Given this list of marker genes ALKBH1, FARS2, THG1L, RARS1, MRPS27, IARS2, NSUN3, EEFSEC, TRMT10B, ELP5, TRMT1L, RPL35A, TRNAU1AP, EARS2, EIF5B, NSUN2 (NOP2/Sun RNA methyltransferase 2), SLFN11, SSB, RPUSD4, TRMU, EIF1AX, KARS1, EIF2AK4, AARS1 (NCBI Gene Id 16), NAT10, PSTK, TERT, AIMP1, SARS2, FARSA, EIF2S3B, GTPBP1, EIF1AY, TRMT1, ALKBH8, DTD1, MTRFR, PUS1, CARS1, THUMPD3, HSD17B10, DTD2, TRMT10C, ELP3, XPO5, EIF2A, MARS1, IGHMBP2, METTL1, DARS2 (NCBI Gene Id 55157), DALRD3 (NCBI Gene Id 55152), SEPSECS, YRDC, XPOT, TYW5, IARS1, NEMF, CTU1, MTRES1, CTU2, SARS1, TARS1, DUS2, TRMT10A, YARS1, YARS2, ELP1, PTRH1, WDR6, QTRT2, EIF2S3, TRMT11, AARS2, IFIT5, GTSF1, SLFN13, TRMT9B, NSUN6, PTCD1, EEF1A1, TRNT1, here is a description of the gene set: studied in species Homo sapiens Human Gene Set: GOMF_TRNA_BINDING Binding to a transfer RNA.